Given this list of marker genes BCL2L14, KCNJ2, RNF19B, GTF2A1, NLRP3, NKX3-1, TWSG1, ASIC4, PRKD2, SRC, OAS2, MMP1, CUL4B, IFI35, GTPBP2, INHBA, SCARF1, ADPRH, TENT5C, C4BPB, PLAU, SNAP25, CFLAR, USP15, TAP2, SEPTIN10, RBBP6, ADAM19, IFNG, CHIC2, ELK4, FGD2, NSUN6, N6AMT1, RRBP1, ABTB2, GEM, PTGS2, C19orf73, DHX15 (DEAH-box helicase 15, NCBI Gene Id 1665), TENT5A, JAK2, GNG5, NBN, IL15RA, TNFAIP8, QKI, GK3, APOBEC3B, BAZ1A, CYLD, TCN1, CCL4, SERPINB8, RBCK1, IL18RAP, CNDP2, PSMB8, AGFG1, B4GALT1, P2RY14, PARP8, CD47, ARL8B, BCOR, HCAR3, TMEM187 (transmembrane protein 187), TMEM255A, LGSN, OASL, LINS1, TIPIN (TIMELESS interacting protein), THRB, CD164, OTUD7B, IL1A, CHST12, CLIC2, MSL3 (MSL complex subunit 3), FFAR2, ITK, IFITM1, CCNL1, LY6E, ICAM1, APOBEC3A (NCBI Gene Id 91577), NDUFV2, ELMO2, UBA7, SERPINA4, SBNO1, ZCCHC2, ACVR2A, GTF2I, ICAM5, HSP90AA1, MT1E, IRS1, TRIM5, LMNB1, IL10, TRIM22, FCGR2B, GATA6, STAP1, EML4, EZH2, S100A14 (NCBI Gene Id 57402), TOR3A, CCSER2, OAS1, RBM7, ZC3HAV1, BID, USP25, HLA-DOB, AFF1, TRAFD1, CASP5, MAT2B, ARHGAP6, IL2RA, MX2 (MX dynamin like GTPase 2), RNF122, MPZL2, RAB29 (RAB29, member RAS oncogene family), SUMO4, SPSB1, JUP, IL19, HSPA1A, EPB41L1, STC2, PPP1R16B, RBPMS, ETV7, B3GNT2, UBE2L6, CAPN5, BLVRA, PIM1, VTN, TRIM25, ERCC6L, MYC, GIMAP4, LPIN2, PMAIP1, MT2A, GPR171, APOL1, NOX3, CLIC4, BAG1, XAF1, FGF5, SLC22A11, BCL6, CCR7, ARID5A, KCNA3, STX12, IRF9, N4BP1, TRIM36, MARCKS, BACH1, TNFRSF4, TRANK1, LGALS9, DNAAF1, SLC7A5, BAK1, COBLL1, RPS6KA5, SOD2, FANCA, KMO, C6orf62, TRAF1, NMI, AGRN, MYD88, LDLR, GIMAP6, IL12RB2, EHD4, IER2, PDE4B, OR2B2, ULBP1, ACSL1, BMX, ADCYAP1, TXN, IGSF6, C3, PLAUR, here is a description of the gene set: species: Homo sapiens The immune responses generated by YF-17D by profiling genes in PBMCs from 2 donors cultured with YF-17D vaccine were accessed after 3 and 12 hours. Genes down-regulated in comparison of unstimulated peripheral blood mononuclear cells (PBMC) cultured for 3 h versus PBMC cultured for 3 h with YF17D vaccine. from publication Querec TD, Akondy RS, Lee EK, Cao W, Nakaya HI, Teuwen D, Pirani A, Gernert K, Deng J, Marzolf B, Kennedy K, Wu H, Bennouna S, Oluoch H, Miller J, Vencio RZ, Mulligan M, Aderem A, Ahmed R, Pulendran B (PMID 19029902) Human Gene Set: GSE13484_3H_UNSTIM_VS_YF17D_VACCINE_STIM_PBMC_DN